Given this list of marker genes DCAF15, ARF3, EPRS1 (glutamyl-prolyl-tRNA synthetase 1), BZW2, MSMO1, ACOT7, CCNB1, ERP29, TMPO, PBK, NR1H4, FANCI, PLA2G15 (NCBI Gene Id 23659), PSMD11, ATP13A1, MRPL18 (mitochondrial ribosomal protein L18), BARD1, YIPF2, GADD45A, BUB1B, SPTLC1, UBE2V2, ARPC3, PRC1, BUB1, SMC4, RTCA, NADK, TAF9, WSB2, MCM2, CDCA3, ARPC5L, TOP2A, PARPBP, ENSA, TNPO3, PSME4, BUB3, TUBA1A, HMGCR, RACGAP1, RARS1, XPOT, STX12, UFD1, CD164, INHA, RHOBTB3, TMEM30A, SNRPA1, MTF2, ANKHD1, UBE2S, MAPRE1, PI4KB, CDK17, HDAC1 (NCBI Gene Id 3065), PRRC2C, STOM, ZMPSTE24, HMGB2, ZWILCH, SART3, DOLK, GMNN, STXBP1, TUBB4B, ICMT, BABAM1, TMEM131L, TPX2, GGH, AREL1 (NCBI Gene Id 9870), FDFT1, ACSM3, KMT5AP1, RFC5, PSMC6, NEK2, ELOVL6, SNX6, KDM4B (lysine demethylase 4B), KIF14, KIF3C, SLC20A1, DYNC1H1, MAD1L1, KIF18B, PCLAF (NCBI Gene Id 9768), ATP6V1G1 (ATPase H+ transporting V1 subunit G1), SLC1A3, DICER1, DNAJC6, DNAJB1 (NCBI Gene Id 3337), LSM5, ERG28, TCP1 (t-complex 1), PDE4B, PTTG1, NRAS, LGALS8, DHCR7, TFCP2, UBE2K, PPIA, RAD23B, CDK1 (NCBI Gene Id 983), CMC2, CEP43, COL4A2, MYO9B, LSS, QTRT2, JAG1, UBL5, ESPL1, BRD3, SLC31A2, FABP3, TDG, OAZ1, HSF2, SKP2, PANK3, PSMB7, HSPA13, GAPVD1, MLF1, ZBTB43, MVD, CEBPG, IL32, KIF1B, NEU1, RIOK3, TNPO1, HOXA9, DCTN2, XPO6, LSM4, SC5D, TRIM52-AS1 (TRIM52 antisense RNA 1 (head to head)), CDC25C, ACLY, HMGCS1, TXN, ANXA4 (annexin A4), AURKA, RFWD3, CCNE1, TPD52L2, POLE3, ANKMY2 (ankyrin repeat and MYND domain containing 2), GNG5, JAKMIP2, SLC7A5, SQLE, ACTR2, EXTL2, CAND1, XPO1, IGF2BP3, NPTX2, CHAF1A, ZWINT, MCUR1 (NCBI Gene Id 63933), ASPM, PTP4A2, SLC7A11, GLRX2, KHNYN, MED8, FGFR4, PSMD14, TMEM41B, GPR89B, POLR2K, PLXNC1, PIGK, TARBP2, TWF1, TUBA1C, SRPRB, SLC36A1, CLINT1, RTN4, CDC25A, ORC6, NAA35, DNMT1, RAD1, TBK1, EZH2, DPP3, GNRHR, IGF2R, IARS1, CCT6A, WDR77, CDC23, GAPDH, MICB, TBC1D13, RNF34, ABCC1, FBN2, CDK8, RDH11, SLC16A1, TMEM97, INTS7, GRIN2C, MARS1, PCYOX1L (NCBI Gene Id 78991), PSMA3, CENPM, P4HA2, H2AZ1, GLO1, TXNDC9, CDK5RAP2, FGFR1, ENO1, DDA1 (NCBI Gene Id 79016), TNFAIP3 (NCBI Gene Id 7128), EBP, PCSK6, NNT, CAPZA1 (NCBI Gene Id 829), PRDM4, CDC123, TMED9 (transmembrane p24 trafficking protein 9), TSC1, ELF4, FDPS (farnesyl diphosphate synthase, NCBI Gene Id 2224), EIF2S2, TUBA1B, FAM32A, CNOT8, DAP3, KIF20A, ACAT2, DTL, ATP6V0B, KIF5B, COPE, ELMO2, DNAJB6, MELK, VPS41, DDX39A, SCD, MAPK6, CAD, STC1, HSD17B7, SLC2A6, SNX24 (sorting nexin 24), HOMER1, SPARC, KPNA3, MTHFD2, LPIN1, PMAIP1, VDAC1, BICD2, RRM2, SLC35D1, E2F6, RPAP3, CENPF, RALGPS1, MED27, NOL8, SUCO, MICA, RPN2, IGF2, PSMC2, CEP76, SMARCA4, YKT6, PIR, MVK, FOXM1, CYP51A1, PLEKHB2, SLC25A24, NUDT1, TUBB2A, ATP1A1, USP14, KIF2C, EPB41L4B (NCBI Gene Id 87974), ANGPT2, RNGTT, TMEM106C, here is a description of the gene set: studied in species Homo sapiens Human Gene Set: WEST_ADRENOCORTICAL_TUMOR_UP Up-regulated genes in pediatric adrenocortical tumors (ACT) compared to the normal tissue. from publication West AN, Neale GA, Pounds S, Figueredo BC, Rodriguez Galindo C, Pianovski MA, Oliveira Filho AG, Malkin D, Lalli E, Ribeiro R, Zambetti GP (PMID 17234769) Pediatric adrenocortical tumors (ACT) are rare and often fatal malignancies; little is known regarding their etiology and biology. To provide additional insight into the nature of ACT, we determined the gene expression profiles of 24 pediatric tumors (five adenomas, 18 carcinomas, and one undetermined) and seven normal adrenal glands. Distinct patterns of gene expression, validated by quantitative real-time PCR and Western blot analysis, were identified that distinguish normal adrenal cortex from tumor. Differences in gene expression were also identified between adrenocortical adenomas and carcinomas. In addition, pediatric adrenocortical carcinomas were found to share similar patterns of gene expression when compared with those published for adult ACT. This study represents the first microarray analysis of childhood ACT. Our findings lay the groundwork for establishing gene expression profiles that may aid in the diagnosis and prognosis of pediatric ACT, and in the identification of signaling pathways that contribute to this disease.